The following is a description of a gene set: Binding to a CCR1 chemokine receptor. Mouse Gene Set: GOMF_CCR1_CHEMOKINE_RECEPTOR_BINDING studied in species Mus musculus, and this is the list of marker genes: Ccl4, Ccl6, Ccl9, Ccl3, Ccl7, Creb3, Ccl5 (NCBI Gene Id 20304)